Given this list of marker genes POLR2J, AGO2, AGO4, PRKRA, BCDIN3D, MIR23B, DGCR8 (NCBI Gene Id 66034), MIR145, POLR2D, RAN, POLR2I, XPO5, POLR2A, POLR2H, DICER1, POLR2B, AGO3, POLR2G, POLR2L (NCBI Gene Id 5441), AGO1, POLR2C, TARBP2, POLR2F, DROSHA, POLR2K, POLR2E, here is a description of the gene set: Reactome Pathway: MicroRNA (miRNA) biogenesis Biogenesis of microRNAs (miRNAs) can be summarized in five steps:<br>1. Transcription. miRNA transcripts may come from autonomously transcribed genes, they may be contained in cotranscripts with other genes, or they may be located in introns of host genes. Most miRNAs are transcribed by RNA polymerase II, however a few miRNAs originate as RNA polymerase III cotranscripts with neighboring repetitive elements. The initial transcript, termed a primary microRNA (pri-miRNA), contains an imperfectly double-stranded region within a hairpin loop. Longer sequences extend from the 5' and 3' ends of the hairpin and may also contain double-stranded regions. <br>2. Cleavage by DROSHA. The 5' and 3' ends of the pri-miRNA are removed during endoribonucleolytic cleavage by the DROSHA nuclease in a complex with the RNA-binding protein DGCR8 (the Microprocessor complex). The cleavage product is a short hairpin of about 60 to 70 nt called the pre-microRNA (pre-miRNA). <br>3. Nuclear export by Exportin-5. The resulting pre-miRNA is bound by Exportin-5 in a complex with Ran and GTP. The complex translocates the pre-miRNA through the nuclear pore into the cytoplasm. <br>4. Cleavage by DICER1. Once in the cytoplasm the pre-miRNA is bound by the RISC loading complex which contains DICER1, an Argonaute protein and either TARBP2 or PRKRA. DICER1 cleaves the pre-miRNA to yield an imperfectly double-stranded miRNA of about 21 to 23 nucleotides. At this stage the double-stranded miRNA has protruding single-stranded 3' ends of 2-3 nt. <br>5. Incorporation into RNA-Induced Silencing Complex (RISC) and strand selection. The double-stranded miRNA is passed to a Argonaute protein contained in the RISC loading complex. One strand, the passenger strand, will be removed and degraded; the other strand, the guide strand, will be retained and will guide the Argonaute:miRNA complex (RISC) to target mRNAs.<br>The human genome encodes 4 Argonaute proteins (AGO1 (EIF2C1), AGO2 (EIF2C2), AGO3 (EIF2C3), AGO4 (EIF2C4)), however only AGO2 (EIF2C2) can cleave target mRNAs with perfect or nearly perfect complementarity to the guide miRNA. For complexes that contain AGO2, cleavage of the passenger strand of the double-stranded miRNA accompanies removal of the passenger strand. Complexes containing other Argonautes may use a helicase to remove the passenger strand but this is not fully known. The resulting miRNA-loaded AGO2 is predominantly located in complexes with TARBP2 or PRKRA at the cytosolic face of the rough endoplasmic reticulum. AGO2, TARBP2, and DICER1 are also observed in the nucleus. part of: Gene Silencing by RNA species: Homo sapiens